Given this list of marker genes RASGRP2, IGHV1-69, IGHV1-2, DET1, KIR3DL2, TUBA8, TUBB6, PRKCQ, TUBA3D, NECTIN2, FBXW12, CUL5, SH2D1B, YES1, KIF4B, ASB12, DYNC1I1, UBE2L6, SIGLEC11, ASB5, LILRB3, RNF34, IGHV2-70 (immunoglobulin heavy variable 2-70), RNF220, TREM2, TNFRSF14, UBE2E1, VAMP3, KLHL2 (NCBI Gene Id 11275), CD300LD, BLNK (B cell linker), FBXO6, TRAV29DV5, COL1A1, TPP2, CD1C, KLC1, ASB15, TRIM69, TRIM63, IGKV2D-30, PSMA6, RASGRP3, PTEN (NCBI Gene Id 8037), SLAMF7, NFATC3, BLK (BLK proto-oncogene, Src family tyrosine kinase), PPP2R1B, HMGB1 (NCBI Gene Id 3146), DZIP3, TRIM11, TREML4, SH3KBP1, PDIA3, LRRC41, BTK, HERC2, TRIM9, PAK2, TUBA3E, IGHM, AHCYL1, HLA-DOB (major histocompatibility complex, class II, DO beta), CD101, UBE2Q2, CD86, KIF3C, HERC4, BLMH, RNF114, CD300LG, ITGB7, LAIR1, PSMB4, SKP2, JAML, IGKV1D-33, LILRA2, PAK3, PIK3R6, UBE3B, ANAPC4, SEC61A1, KLHL3, SIGLEC9, CDC23, TRAF6, PPP2R5B, IGKV4-1, MYD88, FBXW8, PIK3AP1, HLA-DRB3, UBE2S, ANAPC1, SAR1B, REL, CLTA, IGLV2-14, PRKG1, ICAM4, IGKV1-5, FBXW5, CD1A, SH2D1A (SH2 domain containing 1A), CLEC2D, TRAT1, LNPEP, TRAV8-4, HECTD3, ASB6, UFL1, MLST8, FBXO40, SIPA1, KLRK1, KIF26A, BTLA, ASB9, KIR2DL1, SEC31A, ZNRF2, CD34, TAB2, RACGAP1, BTNL2, PJA2, PSMB9, UBA7 (ubiquitin like modifier activating enzyme 7), CAPZA2, SELL, DNM3, AP2M1, ERAP1, ZBTB16, B2M, ITGAV, CD81, RNF19A, PIK3CG, KIF5A, ARF1, UBE3C, PSMD2, IGHV4-39, ICAM3, RBBP6, LILRB1, PSMD7, FBXO41, IGKV3D-20, HSPA5, BTBD6, FGB, CD300LB, ACTR1A, RAET1E, BCL10, HLA-DPB1, CENPE, UBE2F, CD8A, DCTN6, TUBB4B, CDC20, KIR3DL1, ELOB, MAP3K8, PLCG1, NFKBIB, MAP3K14, IGKV3-20, FBXL12, HERC3, FBXL3, CLEC2B, KBTBD6, PSMD14, CD209, BTRC, IGLC3, CUL7, PRKN, IGHV4-59, MYLIP, PSMC6, HECW2, MGRN1, CD300LF, IGHD, DYNC1LI1, OSCAR (NCBI Gene Id 126014), BTN3A2, FBXL18, DYNLL1, HLA-DPA1, CTSV, IGKV5-2, ITGB1, RPS27A, KIR2DS2, SRC, SEC22B, CCNF, KLHL9, KLHL25, FBXW2, RNF213, FBXO4, FBXW11 (F-box and WD repeat domain containing 11), NCR1, RAF1, FBXL20, HLA-DQB1 (NCBI Gene Id 7924, major histocompatibility complex, class II, DQ beta 1), IGHV3-48, CXADR, PSMA2, SIGLEC7, DCAF1, CUL2, SOCS1, PRKACG, NFATC1, TLR1, TRIM41, PSMB2, TAP1, PSMD8 (proteasome 26S subunit, non-ATPase 8), WWP1, CDC42 (NCBI Gene Id 998), TLR4, CTSE, PLCG2 (NCBI Gene Id 5336), FCGR2B, CAPZB, HLA-DOA, UBAC1, PSMC3, COLEC12, TUBAL3, HLA-DQA2, ASB10 (NCBI Gene Id 2726), UBE2J1, MTOR, HRAS, DCTN1, ITPR3, SPSB1, UBE2Q1, RNF19B, FCGR1BP, HLA-DRB1, FCGR1A, PSMC4, HLA-DRB4, IGHV3-13, IGLV2-8, KIF2A, CTSC, GRB2, SPSB4, RLIM, CUL1, AP2A2, KCTD6, ATG7, CTSO, FBXL4, TUBB8, FBXO27, PSMB5, UBA52, COL3A1, LILRA6, MICA, IGLV1-44, CD300E, NCF4, TLR2, CD300C, CD40, TRIM21, IGLV6-57, RNF130, UBE2N, ASB8, TUBA4A, UBR4, CD1D, UNKL, CRTAM, BECN1, ANAPC13, KRAS, KIF11, LAT, CD200, WAS, SH3RF1, ANAPC10, ICOSLG (inducible T cell costimulator ligand), ITPR1, PRR5, FBXL14, KIF2C, SEC61B, CD99, GRAP2, IGLV3-25, S100A1, SEC23A, LILRB4 (leukocyte immunoglobulin like receptor B4), DNM1, PIANP, PPIA, UBE2K, PSMD13, CTSH, CTLA4, UBB, NFKBIA (NCBI Gene Id 4792), NCF2, ICOS, PSMC5, NRAS, RIPK2, PSMA1, LONRF1, KIF18A, STUB1, LAIR2, HUWE1, CANX, BTN2A1, SEC13, UBE2D4, MADCAM1, AP1G1, SFTPD, HLA-DRA, SIGLEC10 (NCBI Gene Id 89790), PSME2, ICAM5, TRIM50, ELOC, HACE1, RILP, RNF126, NPDC1, IGKV1-33, FBXO21, IGKV1D-16, IGKV3-11, KEAP1, TRAIP, CD40LG, UBE2D1, CD74, KLC4, FBXL7, UBE3D, TREML2, UBE2M, TRIB3, IFITM1, MICB, MEX3C, LRSAM1, GAN, RNF41, UBE2L3 (NCBI Gene Id 7332), CD300A, ASB3, PJA1, LAG3, UBE2D3, COL1A2, PPP3CB, CDC16, KIF23, RNF14, UBE2D2, ITCH, PDCD1, CD200R1, UBE2H, PSME1, IGKV1-39, RAC1, CD96, PSMA7, KIF2B, RBCK1, KCTD7, TRIM4, KLC2, CTSD, AP1S1, DNM2, IKBKB, PTPN22, CUL3, FBXO7, FGA, SIGLEC6, PSMB6, PSMC2, CDC26, KLRG1, ARIH2, TUBB1, IGLV1-40, SIGLEC5, LMO7, PPP2R5E, THEM4, ANAPC7, CD79B, LCK, TAPBP, MRC2, FBXO11, IGHV3-30, KIF3A, SLAMF6, IGHV3-53, ASB14, IGKV1-17, IGLV1-51, SEM1, RNF138, RAP1GAP2, KLHL22, MALT1, PTPN11, RAP1GAP, CDH1, SOCS3, MIB2, HCST, KLRF1, KLHL11, CD3D (NCBI Gene Id 915), IGHV3-23, SEC24D, CD4, UBA1, SIGLEC8, LILRA5, SIAH1, NFKB1, RNF6, PPP2CA, ANAPC2, RELA, ITK (NCBI Gene Id 3702), IGHV4-34, CD33, LGMN, IGKV1D-12, NCF1, IGHV1-46, ICAM2, CDC34, KIF15, TRBV7-9, LCP2, ATG14, DYNLL2, PPP2CB, ENAH, AREL1, TUBA1A, RNF111, UBOX5, CD22, TRAV19, CD274, BTN1A1, CYBB, NCR3, WSB1, AP2S1, ASB7, AKT3, UBE2O, BTN3A1, UBE2V2, KLHL13, IGLV3-19, ZNRF1, YWHAZ, KIF5B, IGLV3-21, UBE2V1, FZR1, SEC61A2, RNF144B, UBE2W, IGLV2-23, SIGLEC12, IGLV7-43, KIFAP3 (NCBI Gene Id 22920), PVR, RASGRP1, BTN3A3, NCR2, DYNC1LI2, KLRD1, S100A9, IGKV2-28, RNF182, HECTD1, PIK3C3, PIK3R1, TRAF7, CSK, UBA3, TUBB2A, FBXO32, PSMD12, UBE2C, NFKBIE, KBTBD13, KIF4A, CD1B, PRKCB, LTN1, FBXW10, IGHV3-11, THOP1, BTNL8, AKT1, UBE2Z, UBC, CTSK, IGKV2D-40, TRIM36, PSMB8, PPP2R5D, IGKV1-12, CD247, CTSA, LILRA1, SYK, MAPKAP1, RNF4, RBX1, COL2A1, FBXO9, PIK3R2, PPP2R5A, ANAPC5, CD28, TRIP12, PILRA, RAP1A, CDC27, DAPP1, PIK3CB, IGKV1-16, FBXL13, ASB13, TUBA1B, LY96, DCTN3, MRC1, TUBA3C, HERC6, IFI30, NPEPPS, TUBA1C, CD207, BCAP31, FKBP1A, TREM1, RAP1B, PILRB, DCTN4, IGLV3-27 (immunoglobulin lambda variable 3-27), CTSB, SPTBN2, PTPRJ (NCBI Gene Id 5795), SEC24C, ASB4, PIK3CD, RCHY1, PAK1, LNX1, ASB17, FBXO31, FBXO15, NEDD4, ANAPC11, ITGB5, SEC24B (NCBI Gene Id 10427), CBLB, HLA-G, TUBB2B, PPP2R1A, UBE2G1, SEC61G, DCTN2, RNF7, ASB1, TLR6, FCGR3A, VHL, PSMB7, RICTOR, SKP1, LILRA3, CD79A, UBR1 (ubiquitin protein ligase E3 component n-recognin 1), RAPGEF3, GLMN, PSMA3, UBE2B, UBE3A, PSMA5, HECTD2, IGKV2-30, PTPN6, KIF20A, HLA-C (major histocompatibility complex, class I, C), AP2A1, SH3GL2, KLRC1, PSMC1, C3, TRIM39 (tripartite motif containing 39), CHUK, DTX3L, LILRB5, KLHL41, UBE2E2, COL17A1, PIK3R5, CD14, MAP3K7, HLA-DMA, AP2B1, PDCD1LG2, FBXO2, IGHV2-5, YWHAB, TUBB3 (tubulin beta 3 class III), RNF25, PPP2R5C (protein phosphatase 2 regulatory subunit B'gamma), VAMP8, CD8B, CYBA, S100A8, TRIM37, PSMB3, RNF123, RNF115, PIK3CA, SOS1, KIR2DS1, HLA-E, TRPC1, SIAH2, FYN, ASB11, KIF22, ITGAL, SIGLEC1, UBE2J2, KLHL20, UBR2, UBA5, KIF3B, NCR3LG1, KIR2DL2, ACTR10, NEDD4L, KLRB1, SMURF2, PDPK1, CARD11, VASP, KLC3, VAV1, DYNC1H1, IGLV2-11 (immunoglobulin lambda variable 2-11), STIM1, KBTBD8, ORAI1, CALM1, UBE2R2, HLA-DMB, UBE2A, PAG1, FBXO10, CD226, CLEC4G, IKBKG, RAB7A, LILRB2, LRR1, TUBA4B, PPP3R1, SMURF1, KLHL5, FBXL5, FBXW4, ITPR2, UBE4A, ORAI2, HLA-B, INPP5D (inositol polyphosphate-5-phosphatase D), CLTC, HLA-DQB2, IGKV3-15, CTSS, ZAP70, PSMD6, KBTBD7, CD160, TUBB8B, IGLV1-47, AP1M1, CD80, VCAM1, PIK3R4, FBXO22, IGKV1D-39, DCTN5, IGHV3-7, NFATC2, HLA-F, OSBPL1A, FGG, ITGB2, HERC1, ITGA4, FBXW9, LYN, CD3G, PIK3R3, ULBP1, FBXW7, PPP3CA, EVL, IGLV3-1, MKRN1, KLHL21, FBXO30, PSMA4 (NCBI Gene Id 5685), RAPGEF4, PSMD3, FBXO44, TREML1, HLA-DQA1, CALR, FBXL8, SEC24A, ACTR1B, ERAP2, KIR2DL4, ASB16, FBXL19, FBXL15, IGHV3-33, PRKACB, CTSL, STX4 (syntaxin 4), UBE2G2, CAPZA3, TYROBP, ASB2, HLA-DRB5, CBLL2, AP1B1, ULBP3, BTN2A2, UBA6, PSMB1, SPSB2, PSMB10 (NCBI Gene Id 8138), KLHL42, AP1S3, TRIM32, AP1S2, UBE2E3, FBXL22, FBXO17, CD36, IGLC2 (NCBI Gene Id 3538), BTNL9, TAP2 (transporter 2, ATP binding cassette subfamily B member), AP1M2, ASB18, LILRA4, PRKACA, RNF217, TRBV12-3, UBE2U, ICAM1, TIRAP, HERC5, PTPRC, PSMD1, KIR2DL3, PSMD11, ADRM1, CTSF, SNAP23, BTBD1, FBXL16, TRIM71, NCK1, DYNC1I2, CAPZA1, FYB1, PPL, HLA-A, AKT2, CD3E, CD19, XDH, IGKV2D-28, TUBB4A, here is a description of the gene set: species: Homo sapiens Human Gene Set: REACTOME_ADAPTIVE_IMMUNE_SYSTEM Adaptive Immune System